Given this list of marker genes GPC4, XPO1, TLR6, GPC2, TLR7, MED10, MED17, MED13L, SPCS2, RAB5B, SEC11A, MED13, MED14, MAVS, H2BC15, SDC2, EIF2AK2, JAK1, CCNC, BECN1, SPCS3, IFNA14, OAS2, MED28, MED11, HSPG2, MAP1B, IFNAR1, IFNA5, LY96, MED6, CREBBP, SEC11C, CSNK2A2, MED9 (NCBI Gene Id 55090), MED1, MED27, RAB5C, CD14 (NCBI Gene Id 929), MED4, PPP1CB, IFNA7, IFNA17, MED29, ARIH1, IRF3, CDK19, GPC5, SPCS1, CLEC4M, FURIN, ISG15, STAT2, IFNA2, IFNB1, MED15, KPNB1, RAB5A, RBX1, IFNA13, IFNA6, EP300, SDC4, HSP90AA1, TYK2, PPP1CC, AGRN, SDC1, MED21, TLR3, CDK8, MED7, NCL, PPP1CA, TLR2, RPS27A, MED26, MED22, UBB, IFIH1, IFNA1, GPC3, ELOC, MED8, HSPA8, CX3CR1, UBC, CSNK2B, IFNA10, GPC1, IFNA4, MED30, MED25, GPC6, TLR4 (NCBI Gene Id 7099), HERC5, MED16, SDC3, MED23, UBE2L6, CD209, TRIM25, IFNA21, IFNAR2, MED24, IFNA8, EGFR, HSP90AB1, IGF1R, MED31, CUL5, ELOB, IFNA16, UBA52, BCAP31 (B cell receptor associated protein 31), CSNK2A1, RIGI, MED18, MED12, MED20, MED19, here is a description of the gene set: studied in species Homo sapiens Human Gene Set: REACTOME_RESPIRATORY_SYNCYTIAL_VIRUS_INFECTION_PATHWAY Respiratory Syncytial Virus Infection Pathway